Given this list of marker genes TP53I3, CBR4, NQO1, RTN4IP1, CBR3, ADH4, CRYZ, CRYZL1, here is a description of the gene set: Human Gene Set: GOMF_NADPH_DEHYDROGENASE_ACTIVITY species: Homo sapiens Catalysis of the reaction: NADPH + H+ + acceptor = NADP+ + reduced acceptor.